Given this list of marker genes Pkm, Vamp3, Btla (B and T lymphocyte associated), Atp6v1b2, Sav1, Llgl1, P4ha1, Paics (phosphoribosylaminoimidazole carboxylase, phosphoribosylaminoribosylaminoimidazole, succinocarboxamide synthetase), Osmr, Aldoa, Rbm47, Grhl2, Snap23, Phaf1, Thbs2, Rce1, Sptbn4, Car10, Grb10 (growth factor receptor bound protein 10), Dhx36, Pgap3, Dagla, Wdr47, Idh3g (NCBI Gene Id 15929), Urm1, Cd247, Rbfox1, Tmed3, Csnk1g1, Prdm15, Nkain2 (Na+/K+ transporting ATPase interacting 2), Prickle3, Sox10, Ing3, Arfip2, Smarcd1, Phospho1, Slc39a3, here is a description of the gene set: Genes predicted to be targets of miRBase v22 microRNA mmu_miR_3060_5p in miRDB v6.0 with MirTarget v4 prediction scores > 80 (high confidence targets). from publication Chen Y, Wang X (PMID 31504780) studied in species Mus musculus Mouse Gene Set: MIR_3060_5P